Given this list of marker genes Fshr, Cln3, Sct, Sctr, Slc6a12, Aqp4, Aqp1, Aqp11, Anxa7, here is a description of the gene set: Mouse Gene Set: GOBP_INTRACELLULAR_WATER_HOMEOSTASIS A homeostatic process involved in the maintenance of a steady state level of water within a cell. studied in species Mus musculus